Given this list of marker genes RXRA, ABCG8, ABCG5, CYP7A1, NR1H3 (nuclear receptor subfamily 1 group H member 3), FASN, SREBF1, SCD, CYP3A4, CYP2B6, here is a description of the gene set: Human Gene Set: WP_LIVER_X_RECEPTOR_PATHWAY studied in species Homo sapiens Liver X receptor pathway